The following is a description of a gene set: studied in species Mus musculus Mouse Gene Set: chr4C4, and this is the list of marker genes: Gm13278, Gm12420, Gm13284, Cntln, Mir491, Scarna8, Haus6, Cdkn2a, Sh3gl2, Ifnz, Ifnb1, Dennd4c, Gm13287, Ifna16, Gm13271, Gm13282, Mrpl48-ps, Ifna2 (interferon alpha 2), Gm13288, Hacd4, Gm12602, Gm13272, Gm12610, Mllt3, Gm26017, Ifna11, Gm12606, Ifna15 (interferon alpha 15), Gm13281, Gm13279, Cdkn2b, Acer2, Gm26490, Gm12413, Gm12551, Gm13275, Gm13276, Gm25811, Saxo1os, Pramel32 (NCBI Gene Id 97185), Rraga, Wincr1, Gm12414, Rps6, Gm13289, Ifne, Gm12604, 4930553M12Rik (NCBI Gene Id 75246), Ifna7, Gm49890, Saxo1, Adamtsl1, Gm13290, Klhl9, Focad, Mir31, Gm12607, Gm12419, Ifna5, Gm13274, Ifna14, Gm12608, Ifna1, Bnc2, Gm12418, Ifna9, Ifna4, 6030471H07Rik, Gm13286, Gm12630, Ifna13, Slc24a2, Ifna12, Ifna-ps1, Gm12416, Gm13277, Mtap, Gm13283, Plin2, Ifnab, Dmrta1, Ifna6, Gm13285, Tgif2-ps1, Gm12415